The following is a description of a gene set: studied in species Homo sapiens Any process that activates or increases the frequency, rate or extent of monocyte differentiation. Human Gene Set: GOBP_POSITIVE_REGULATION_OF_MONOCYTE_DIFFERENTIATION, and this is the list of marker genes: IL34, DCSTAMP, ACIN1, FES, CSF1, CD74, CTNNBIP1, CD4, HLA-DRB1, ZFP36L1